Given this list of marker genes COL1A1, BECN1, CCND1, ALAD, LEP, CAT, GPX1, here is a description of the gene set: studied in species Homo sapiens Any process that results in a change in state or activity of a cell or an organism (in terms of movement, secretion, enzyme production, gene expression, etc.) as a result of a vitamin E stimulus. Human Gene Set: GOBP_RESPONSE_TO_VITAMIN_E